Given this list of marker genes RIGI, UBA52, NUP50, NUP54, NUP133, SNRPF, TRIM25, AAAS, YWHAQ, RPS5, HLA-F, IFNA5, IFNB1, TRAF3, JAK1, SNRPG, TAB1, UBC, RPS15A, AKT1, TLR2, RPS21, GEMIN8, SNRPD2, IKBKG, IKBKB, IFNAR1, IFNA6, RPS17, TRIM4, TPR, ISG15, GEMIN5, NUP62, PTPN6, IL17RC, VPS18 (VPS18 core subunit of CORVET and HOPS complexes), IFNA8, UVRAG, TBK1, YWHAZ, RPS26, RPS3, TAB2, RPS4Y1, STAT1, RPS4X, AKT3, NUP155, CRB3, PALS1, RPS15, RPS24, PDPK1, RPS20, G3BP2, UBE2V1, IFNA4, SIKE1, IRF3 (NCBI Gene Id 3661), IFNA7, SEC24D, NUP93, RPS2, RPS8 (ribosomal protein S8), SFTPD (NCBI Gene Id 6441), SEC23A, NUP58, IRAK1, G3BP1, RPS16 (NCBI Gene Id 6217), MASP1, YWHAH, NUP85, IRAK2 (interleukin 1 receptor associated kinase 2), SEH1L, FAU, IL17RA, RPS11, SEC24A, KPNA2, CNBP, TOMM70, MAVS, NUP153, VPS16, RPS7, SFN, TLR1, GEMIN4, HSP90AA1, LARP1, ATG14, STAT2, NUP98, GJA1, NDC1, YWHAE, HLA-E, VPS39, NUP35, NOD2, VPS33A, PATJ, IKBKE, IFNA17, HLA-C, RPS10, IFNAR2, NUP205, RPS23, VPS41, HLA-A (major histocompatibility complex, class I, A), NLRP3, POM121C, NOD1, TKFC, NLRP12, IFNA16, TUFM, BECN1, TLR7, VPS33B, UBB, VPS11, IRF7, IFIH1, TAB3, MAP3K7, SEC13, NUP88, YWHAB, RPSA, SNRPE, RPS3A, NUP107, TYK2, GEMIN7, B2M (beta-2-microglobulin), IFNA14, RNF135, SAR1B, NUP210, RIPK2, POM121, CAV1, IFNA2, RANBP2, SEC24B, UBE2N, RPS28, PTPN11, TLR8 (NCBI Gene Id 92553), RPS19, IFNA10, RPS27A, NUP214, GEMIN2, RPS4Y2, SNRPD1 (small nuclear ribonucleoprotein D1 polypeptide), DDX20, HSP90AB1, NUP37, NUP188, RPS27L, NUP160, TRAF6, YWHAG, RPS12, IFNA1, PIK3C3, GEMIN6, TJP1, SNRPB, CHUK, AKT2, STING1, SEC24C (NCBI Gene Id 9632), SMN1, MBL2, IFNA21, HLA-G, RPS6, NUP43, VPS45, RPS27, RPS29, RAE1, RPS25, RPS13 (ribosomal protein S13), NUP42, SMN2, RPS14 (NCBI Gene Id 6208), SNRPD3, PIK3R4, RPS9, IFNA13, IL17F, HLA-B, MASP2, IL17A, MAP1LC3B (NCBI Gene Id 81631), RPS18, CREBBP, here is a description of the gene set: Human Gene Set: REACTOME_SARS_COV_2_HOST_INTERACTIONS SARS-CoV-2-host interactions studied in species Homo sapiens